The following is a description of a gene set: studied in species Mus musculus A clathrin-coated, membrane-bounded intracellular vesicle formed by invagination of the plasma membrane around an extracellular substance. Mouse Gene Set: GOCC_CLATHRIN_COATED_ENDOCYTIC_VESICLE, and this is the list of marker genes: Ap2a2, Tyrp1, Epn2, Myo1e, Snap91, Cemip, Cltc, Ston2, Ngfr, Ston1, Ctla4, Cpne2, Ap2a1, Lmbrd1, Slc5a7, Cpne6, Ap2m1, Ap2b1, Inpp5f, Myo6, Btbd8, Eps15, Tbc1d5, Sgip1, Slc18a3, Ap2s1, Dnm2, Rab35